Given this list of marker genes RPGRIP1L (RPGRIP1 like), WASHC5, GZF1, CHN1, CHD7, ABCB6, SPTBN1, SIX6, TMEM67, BMP4, INPP5E, WAC, ZNF668, MPDZ, C12orf57, SALL1, RBP4, MAFB, CCDC22, SEMA3E, SALL4, ACTB, GDF3, PAX6, BCOR, TBX22, HMGB3, RERE, SHH, TMEM138, ZEB2, VPS35L (VPS35 endosomal protein sorting factor like), PIGL, FZD5, ZNF423, TMEM231, TMEM216, TMEM237, SIX3, CC2D2A, DPYSL5, CEP290, DACT1, NAA10, HMX1, HHAT, CLDN19, MAX, YAP1, AKT1 (AKT serine/threonine kinase 1), PORCN, here is a description of the gene set: species: Homo sapiens Absence of a region of the retina, retinal pigment epithelium, and choroid. Chorioretinal coloboma Human Gene Set: HP_CHORIORETINAL_COLOBOMA